The following is a description of a gene set: Genes up-regulated in peripheral blood mononuclear cell 336h vs 0h in adults (22-54) after exposure to F. tularensis vaccine LVS, time point 336H The live vaccine strain (LVS) of Francisella tularensis is the only vaccine against tularemia available for humans, yet its mechanism of protection remains unclear. We probed human immunological responses to LVS vaccination with transcriptome analysis using PBMC samples from volunteers at time points pre- and post-vaccination. Gene modulation was highly uniform across all time points, implying commonality of vaccine responses. Principal components analysis revealed three highly distinct principal groupings: pre-vaccination (-144 h), early (+18 and +48 h), and late post-vaccination (+192 and +336 h). The most significant changes in gene expression occurred at early post-vaccination time points (<=48h), specifically in the induction of pro-inflammatory and innate immunity-related genes. Evidence supporting modulation of innate effector function, specifically antigen processing and presentation by dendritic cells, was especially apparent. Our data indicate that the LVS strain of F. tularensis invokes a strong early response upon vaccination. This pattern of gene regulation may provide insightful information regarding both vaccine efficacy and immunopathogenesis that may provide insight into infection with virulent strains of F. tularensis. Additionally, we obtained valuable information that should prove useful in evaluation of vaccine lots as well as efficacy testing of new anti-F. tularensis vaccines. from publication Fuller CL, Brittingham KC, Porter MW, Hepburn MJ, Petitt PL, Pittman PR, Bavari S (PMID 17349694) studied in species Homo sapiens Human Gene Set: FULLER_PBMC_F_TULARENSIS_VACCINE_LVS_AGE_22_54YO_336HR_UP, and this is the list of marker genes: ADAMDEC1, FCGR3A, TAP1, CCR5, CD86, IRAK2, TLR8, NOD1, CARD10, CDC42, LILRB4, FCER1A, FCER1G, TLR6, CCR1, TLR1, DCP1B, TLR7, FCGR2A, TLR10, TLR2, NOD2, FCGR1A, CCR2, TLR3, FAS, CCL21, IRAK4, DCTN2, CARD9, TLR5, CCR4, CD1D, ICAM2, CARD8, TRAF6, CCL17, TIRAP, TLR9, HLA-DMB, HLA-DRB1, HLA-DMA, TLR4, CD1C, HLA-DQB1, MYD88 (NCBI Gene Id 4615)